Given this list of marker genes NRAS, PTPN22 (NCBI Gene Id 5779), DZIP1L, CD3E, CTLA4, YARS1, SEMA4D, GPI, TPP2, RNASEH2B, LYST, SNX10, SOS1, BMP6, CFAP45, NCF4, ERBB3, RORC, FYB1, CAVIN1, GSN, RSPH4A, CPLX1, ATP7B, RARB, IFT172, AKT1, KRAS, NLRC4, GLRX5, MS4A1, ODAD1, ZIC3, WT1, RIT1, CD247, NOD2, SAMHD1 (NCBI Gene Id 25939), NOP10, FASLG, IL23R, SAMD9L, PIBF1, CYBA, CYP2R1, MMEL1, RUNX1, VPS13A, RINT1, NBEAL2, RNU7-1, PIK3CG, ZNFX1, TMEM237 (NCBI Gene Id 65062), SLC39A4, SLC29A3, PDPN, CTSK, STXBP2, CPOX, CTSA, CASP10, NPC1, AGA, MCTS1, PTEN, PDCD1, ERAP1, CLPB, MEG3, PSAP, ABCB4, G6PD, MNS1, RTL1, PEX2, PHEX (phosphate regulating endopeptidase X-linked), HSD17B4, SPIB, IL10, GLIS3 (NCBI Gene Id 648268), DNAAF5, COX10, CYBC1, GIMAP5, DRC1, UBR1, UMPS, CD70, AP3B1, GNS (glucosamine (N-acetyl)-6-sulfatase), GYPC, RAB27A, USB1, STIM1, PLEKHM1, LCAT, SHARPIN, GPR35, IDUA, TNFSF11, SETBP1, ATP6AP1, FMO3, ATP6V1B2, SMPD1, SLC4A1, JMJD1C, ADAR, VPS11, PNPLA2, PTPN11, NME8 (NCBI Gene Id 51314), ALG9, CARD11, NAGLU, DNASE1L3, SLC30A10, MICU1, IFNGR1, CYP7B1, IL1RN, SERPINA1, LEMD3, LMNA, WDR35, JAK2, AKR1D1, UBAC2, XIAP, PKLR, ANK1, HLA-DRB1, ADA, PHYH, NAE1, MEGF8, PSMG2, F5, SH2B3, TULP3, CASR, CEP290, GBE1, HBG2, NCF1, NCF2, GPIHBP1, IL2RB, CTC1, TMEM107, TCTN2, CDAN1, CDON, ORAI1, TERC, SLC19A1, HMOX1, GPC3, CD3D, BMP2, FCGR2A, FOCAD, FGA, ALG1, ABCA1, APOC2, MEFV, STEAP3, TNFRSF13C, PIGM, SPEN, DNAAF3, HFE, IL2RG, ADA2, OAS1, SYK, B4GALT1 (beta-1,4-galactosyltransferase 1), CALR, FGFR2, TBXAS1, DDRGK1, YME1L1, LPL, DNAJB13, PRKCZ, DGUOK, DNAAF6, NGLY1, RPGRIP1, DNAAF2, GAA, CFAP300, IRF8, FERMT3, IL6ST, TFE3, MRAS, JAK3, IL6, ABCD3, FAS (NCBI Gene Id 355), TNFRSF11A, ICOS, NOTCH1, PEX7, FUCA1, LZTR1, USP53, RABL3, IL12RB1, RFX5, APOE, LIPA, CA2, OFD1, CCDC32, MED12, TERT, ESAM, STAT4, LSM11, SMAD4, CFC1, NEK8, PALLD, SLC25A13, CFAP298, COX4I2, PALB2, MST1 (NCBI Gene Id 4485), CFAP74, FAH, NLRP3, CHD7, CR2, DNAAF1, EP300, CBL, TALDO1, FAM111A, TWIST1 (twist family bHLH transcription factor 1), NLRP12, OCLN, LAT, INPP5E, IL7R, KCNH1, CFTR, DNAH1, NDUFS4, UNC13D, ANKRD55, AP3D1, ESCO2, MMP21, GP1BB, UROD, HSPG2, SAMD9, VPS33B, LPIN2, RRAS2, RREB1, TGFB1, BCR (NCBI Gene Id 729775), PRKCD, GABRD, BTD, CLCN7, ZNF699, KMT2D, LRRC56, LBR, BRCA1, GDF1, NODAL, OTC, MYC, DNAL1, CCDC47, GPC4, EPB42, RNASEH2A, PRF1, PSMB9, LUZP1, CCDC40, RSPH9, RPGR, MECOM, KDM6A, NFKBIA, SEC24C, PSTPIP1, WNT3, COG4, RBM8A, EXOC2 (NCBI Gene Id 55770), CASP8, TET2, ABCG8, ABCG5 (NCBI Gene Id 64240), SOCS1, SPTA1, ABCB11, CD19, IRF4, NFKB1, RAB23, ALMS1, IARS1, MPIG6B, IFT56, ADAMTS3, TNFSF12 (NCBI Gene Id 8742), SGSH, CD28, ODAD4, BRAF, TPI1 (NCBI Gene Id 7167), INPPL1, VPS45, GATA2, IKZF3, STX11, FOXP3, TINF2, BCL11A, LIG4, TCIRG1, GATA1, PPARG, GAS2L2, MYO5B, POLD3, TCTN1, SCYL1, GCLC, CD40LG, ERCC8, DNAI2, SLC2A1, PNP, NDE1, HBG1, IKBKG, SKI, UFD1, CCR1, CASK, MIF, DNASE2 (deoxyribonuclease 2, lysosomal), LRBA, CCNO, SP110, RASA2, MAP2K1, IFNG, KLF1, ITK, SOS2, SKIC2, CLXN, KCNN3, ATM, DNAI1, CSPP1, RNASEH2C, HCK, CFAP410, SCARB2, TYMS, STAT3, MYD88, CREBBP, TP53, MOGS, ATP8B1, PKHD1 (PKHD1 ciliary IPT domain containing fibrocystin/polyductin), CASZ1, IFT140, FOXJ1, JAK1, NPM1 (NCBI Gene Id 4869), PRIM1, MMUT, INSR, G6PC3, DPM1, NPHP3, ERCC6, SPAG1, TMEM231, GUSB (NCBI Gene Id 2990), FGG, CCDC39, PRDM16, C4A, MKS1, NEU1, KATNB1, BACH2, RPGRIP1L, FARSA, CYP27B1, PSMB10, GEMIN4, AIRE, ASXL1, DNAH9, ARVCF, MCM10, TTC12, GNB2, RFXAP, PTPN2, HK1, TCF3, ODAD3, COMT, EPB41, HMBS, RHD, MAN2B1, KIF3B, CLDN1, COG6, RNF31, DCDC2 (doublecortin domain containing 2), GP1BA, CYBB, IL2RA, KIT, GNE, CD27, HAMP, ALAS2, SLC17A5, SOX10, RAC2, CCDC115, TLR4, PPP2R3C, DYNC2LI1, TNFSF15, NEK10, GALE, CSF3R, PHKG2, LETM1, NOTCH2, IRF2BP2, FAT4, PHKB, AFF4, B9D1, TNPO3, DLL4, BPGM, HYDIN, CD81, ZAP70, HBA2 (hemoglobin subunit alpha 2), NHLRC2, LACC1, CCND1, SAA1, SF3B1 (NCBI Gene Id 23451), RHCE, ABCA12, MYRF, KLRC4, TCTN3, IL12A (interleukin 12A), BCL6, DHCR24, COG7, DLK1, PSMB4, ATRX, WRAP53, RMRP, HGSNAT, SKIC3, ASAH1, MPV17, IRF1, TRPV6, CAV1, TNFRSF1B, KCNAB2, ZEB2, EPOR, GLB1 (NCBI Gene Id 2720), WNT7B, ODAD2 (outer dynein arm docking complex subunit 2), IFIH1, NFKB2, PDGFRA, TNFRSF13B, POU2AF1, UBE4B, HMGA2, CFAP221, ARSB, UROS, SLC37A4, NPC2, HAVCR2, STK36, RERE, RAG1, RAF1, HIRA, PIK3C2A, SPRED2, TNFRSF1A, AGPAT2, TMEM67, ZMYND10, KCNN4, HPGD, RASGRP1, BTNL2, NME5, RAG2, GPD1, DNAAF4, LTBP4, RRAS, PSMB8, MYCN (MYCN proto-oncogene, bHLH transcription factor), DNAH5, TREX1, PEX13, PIGA, SNX14, CDKN2A, ACVR2B, RSPH3, TRAC, HYLS1, MCIDAS, CTNS, WDR1, SPTB, TNFRSF4, TXNDC15, RBCK1, CTBP1, IRF5, TCF4, OSTM1, SPEF2, MCM4, ALDOA, PIK3R1, TBX1, PHKA2, RFWD3, HLA-B, CENPF, COG1, ARPC5, SPIN4, TLR8 (NCBI Gene Id 92553), TNFRSF9, THPO, CCBE1, IDS, GALK1 (galactokinase 1), STAT1, PEPD, RTEL1, PIEZO1, SEC23B, TRNT1, PIK3CA (NCBI Gene Id 5290), ITCH, B9D2, MMP23B, HBB, RHAG, STRA6, DNAAF11, PIK3CD, FOXF1, CDIN1, MVK, SUMF1, FCHO1, SLC7A7, MAGT1, NHP2, COG5, DKC1, CC2D2A, PARN, MPL, VPS33A, NSD2, LYN, IL12A-AS1, POT1, RPSA, FGB, SH2D1A, RELN, SLCO2A1 (NCBI Gene Id 6578), DHCR7 (7-dehydrocholesterol reductase), ABL1, NCKAP1L, NLRP1, DNAH11, HSD3B7, HBA1, ALPK1, DOCK11, BCL2, KPTN, RSPH1, BSCL2, RNU4ATAC, BRCA2, HEXB, ZFYVE19, SRSF2, TMEM216, SMAD2, HJV, PTPRC, GNPTAB, XK, RIPK1, GBA1, FGFRL1, DCLRE1C, here is a description of the gene set: studied in species Homo sapiens Abnormality of the spleen An abnormality of the spleen. Human Gene Set: HP_ABNORMALITY_OF_THE_SPLEEN